Given this list of marker genes CDKN1A, LINC-ROR, ABCB1, HIF1A, LINC00970, MEG3, TP53, BCL2L1, VLDLR-AS1, HOTAIR (NCBI Gene Id 400041), WNT6, here is a description of the gene set: lncRNA-mediated mechanisms of therapeutic resistance Human Gene Set: WP_LNCRNAMEDIATED_MECHANISMS_OF_THERAPEUTIC_RESISTANCE studied in species Homo sapiens